Given this list of marker genes SUZ12, BAZ2A, EED, SIRT1, L3MBTL1, BAHD1, RRP8, CBX3, SIRT2, RB1, YY1, SUV39H1, EZH2, SMARCA5, here is a description of the gene set: species: Homo sapiens Any protein complex that mediates changes in chromatin structure that result in transcriptional silencing. Human Gene Set: GOCC_CHROMATIN_SILENCING_COMPLEX